Given this list of marker genes SLC9A4, SLC9A8, SLC38A5, SLC30A8, SLC17A7, SLC9A3, TMCO3, CHP1, SLC9A7, SLC9A2, SLC11A1, SLC30A5, SLC30A6, SLC9A9, SLC9A1, SLC9A5, SLC30A1, SLC17A6, SLC9A6, GHITM, SLC9C2, SLC38A3, SLC9B2, SLC30A2, SLC9C1, SLC9B1, LETM1, here is a description of the gene set: Human Gene Set: GOMF_METAL_CATION_PROTON_ANTIPORTER_ACTIVITY Enables the transfer of a solute or solutes from one side of a membrane to the other according to the reaction: metal ion(in) + H+(out) = metal ion(out) + H+(in). studied in species Homo sapiens